The following is a description of a gene set: Fatty acids augment the glucose triggered secretion of insulin through two mechanisms: activation of FFAR1 (GPR40) and intracellular metabolism of fatty acids. Fatty acids are transported into the cell by CD36 (FAT) and metabolized by ligation to coenzyme A, transport into mitochondria, and beta oxidation which generates ATP. The ATP increases the intracellular ratio of ATP:ADP and thereby closes potassium channels (K(ATP) channels) at the plasma membrane. The enzymes that metabolize fatty acids in beta cells also metabolize fatty acids in other tissues however their combinations and subcellular locations may differ. part of: Free fatty acids regulate insulin secretion Reactome Pathway: Intracellular metabolism of fatty acids regulates insulin secretion species: Homo sapiens, and this is the list of marker genes: CD36, ACSL4, ACSL3